Given this list of marker genes RBBP8NL, PRAME, CCER1, ZNF556, SOHLH2 (spermatogenesis and oogenesis specific basic helix-loop-helix 2), BEST2, MKRN3, NLRP10, DLGAP4 (NCBI Gene Id 22839), LAMA3, SHISA7, MEFV, NLRP11, ZNF572, HNRNPA3P1, RNF175, ELF3, TRIM29, NLRP8 (NCBI Gene Id 126205), BAHCC1, CACNG7, SCUBE1 (signal peptide, CUB domain and EGF like domain containing 1), KIF2B, IGFLR1, NTF3, NGEF, MAGEB6, FAM135B, TCL1B, CFAP65 (cilia and flagella associated protein 65), JAK3, INSL6, MELK, FAM222B, FRMD4A, here is a description of the gene set: Human Gene Set: HATADA_METHYLATED_IN_LUNG_CANCER_DN species: Homo sapiens from publication Hatada I, Fukasawa M, Kimura M, Morita S, Yamada K, Yoshikawa T, Yamanaka S, Endo C, Sakurada A, Sato M, Kondo T, Horii A, Ushijima T, Sasaki H (PMID 16407832) DNA methylation in the promoter region of a gene is associated with a loss of that gene's expression and plays an important role in gene silencing. The inactivation of tumor-suppressor genes by aberrant methylation in the promoter region is well recognized in carcinogenesis. However, there has been little study in this area when it comes to genome-wide profiling of the promoter methylation. Here, we developed a genome-wide profiling method called Microarray-based Integrated Analysis of Methylation by Isoschizomers to analyse the DNA methylation of promoter regions of 8091 human genes. With this method, resistance to both the methylation-sensitive restriction enzyme HpaII and the methylation-insensitive isoschizomer MspI was compared between samples by using a microarray with promoter regions of the genes. The reliability of the difference in HpaII resistance was judged using the difference in MspI resistance. We demonstrated the utility of this method by finding epigenetic mutations in cancer. Aberrant hypermethylation is known to inactivate tumour suppressor genes. Using this method, we found that frequency of the aberrant promoter hypermethylation in cancer is higher than previously hypothesized. Aberrant hypomethylation is known to induce activation of oncogenes in cancer. Genome-wide analysis of hypomethylated promoter sequences in cancer demonstrated low CG/GC ratio of these sequences, suggesting that CpG-poor genes are sensitive to demethylation activity in cancer. Genes with unmethylated DNA in lung cancer samples.